The following is a description of a gene set: Cytokines mediate cell-cell communication in the immune system and represent important therapeutic targets. A myriad of studies have highlighted their central role in immune function, yet we lack a global view of the cellular responses of each immune cell type to each cytokine. To address this gap, the authors created the Immune Dictionary, a compendium of single-cell transcriptomic profiles of more than 17 immune cell types in response to each of 86 cytokines (>1,400 cytokine-cell type combinations) in mouse lymph nodes in vivo. A cytokine-centric view of the dictionary revealed that most cytokines induce highly cell-type-specific responses. For example, the inflammatory cytokine interleukin-1β induces distinct gene programmes in almost every cell type. A cell-type-centric view of the dictionary identified more than 66 cytokine-driven cellular polarization states across immune cell types, including previously uncharacterized states such as an interleukin-18-induced polyfunctional natural killer cell state. species: Mus musculus Genes positively differentially expressed in cell type: MigDC (migratory dendritic cell) upon treatment with cytokine: TSLP in mouse lymph nodes in vivo. from publication Cui A, Huang T, Li S, Ma A, Pérez JL, Sander C, Keskin DB, Wu CJ, Fraenkel E, Hacohen N (PMID 38057668) Mouse Gene Set: CUI_MIGDC_TSLP_RESPONSE_UP, and this is the list of marker genes: Tspan13 (tetraspanin 13), Trip12, Jak2, Ppdpf, Il10ra, Adgre5, Nup88, Stat5a (signal transducer and activator of transcription 5A), Cd48 (CD48 antigen), Ikzf4, Lima1, Cd274, Serpina3g, Olfm1, Vopp1, Klf6, Relt, Stxbp6, Cyfip1 (cytoplasmic FMR1 interacting protein 1), Coro2a, Rap2a, Tagln2, Ahnak, Atrx, Cytip, Srsf10, Fabp5, Macroh2a1, Pdlim5, Ccl17, Pde1b, Litaf, Mir155hg, Myo1g, Rabep1, Cst3, Rbm3 (NCBI Gene Id 72067), Bcl2l11, Rexo2, Pkib, Gbp5, Traf5, Glipr2, Cish, Gpbp1, Cd86, Ccnd2, Malt1 (MALT1 paracaspase), Nr4a3, Bcl2a1b, Csf2rb, Cdkn1a, Zfand6, C1qbp, Ctsz, St8sia4, Jaml, Lmo2, Samhd1, Pnp, Diaph1, Pim1, Irf5, Pdcd1lg2, Prkcd (NCBI Gene Id 52581), Dclre1c, Prdm1, Rabgap1l, Cd302, Ptpn1, Syngr2, Ptger4, Csnk1d, Orai1, Bcl7c, Nckap1l, Ly75, Fyco1, Fcgrt, Vim, Fgl2